Given this list of marker genes NRG3, VAT1L, ARHGAP12, SULT1E1, EXOC1, SYNJ2BP, RAI14, CAP2, CAPS2, CDKN2B, ADAM19, ZNF711, MGST3, AMOTL2, H2AC6, BEX4, TAGLN, TMEM144, NAP1L3 (NCBI Gene Id 4675), TP53INP2, PTPN14 (NCBI Gene Id 5784), DHRS3, MLLT11, SKP1, NT5E, TUBB2A, PRKCH, ZNF627, NREP, TRIM33, CFAP95, ABI3BP, SCG5, TMEM140, OSTF1 (osteoclast stimulating factor 1), KLHDC8A, C5orf15, SERINC1 (serine incorporator 1), MEAK7 (NCBI Gene Id 57707), ADGRD1, ACTA2, EVA1A, CCN1, PIKFYVE, LMBRD1, IFITM1, KRT18, RAB2B, GPR83, CAVIN1 (NCBI Gene Id 284119), FAM13B, AIG1, CYP26A1, ATP2B4, ATP6V1E1, TGFB2, ATAD1, HTN1, MKRN1, SETX, ITFG1, MYL12B, SCRG1, SLC30A9, ZNF540, RNF103 (NCBI Gene Id 7844), BDH2, ERVFRD-1 (NCBI Gene Id 405754), COX20, IFT52, HTN3, PELO, TPD52L1, PLSCR3 (phospholipid scramblase 3), CCNDBP1, GAB2, ARHGDIB, DKK2, PTPRH, CYLD, PLPP6, CCNG2, TRAFD1, UCHL1, FAM220A, SYT17, RUFY3, USP6, RWDD2A, FGF1, REG3G, ANK2, SNN, SH3BGR, CDK5R1, LANCL1, HIPK2, WNK4, EGR3, BCLAF3, SUSD6, PSEN1, NMRK1, SAMD9L, SLC12A6, FILIP1L, ZSWIM6, OTUD1, YPEL5, ATP9A, TUG1, FAT1, CCDC115, DTX4, GPRASP2, RARA, CFAP20, GNAQ, ATP6V1G1, C18orf32, ANO6, ST6GALNAC3, NCAM2, BCAS3, CXCL8, BMAL1, CTTNBP2NL, TDRP, IFITM3, SMIM14, RND3, RASA1, PICALM, FGD6, TRIM2, GNPTG, PHLDB2, GRB10, PLA2G12A, CD59, TRIM22, WDR47, CPNE3, SST, MAP1LC3B, SCN3A, UBE2A, ANXA3, MYH9, AKAP6, SMYD3, PJA1, GTF2A1, NUB1, AK9, GBP3, NAPB, PAPSS1, FOXC1, FSTL1, SPATA7, THBS2, TAGLN3, FSD1L, FN1, PRSS23, TMSB15B, MMD, PKIG, KLF3-AS1, HMGCL, ZNF419, ZNF879, ADAMTS15, ITGB1, H3C6, KDM7A, EMCN, PRORSD1P, CADPS (NCBI Gene Id 8618), IFNAR2, OPTN, CREM, GABARAPL1, ADM, GPRC5A, ZNF784, CLIP4, GAS2, IFI35, SMIM3, GARNL3, SERPINE1, LINC00847, ITGA2, NUAK1, SRPX, GFRA1, here is a description of the gene set: Genes up-regulated in double positive thymocytes with ELK4 knockout: untreated versus stimulated by anti-CD3. Human Gene Set: GSE21546_UNSTIM_VS_ANTI_CD3_STIM_SAP1A_KO_DP_THYMOCYTES_UP studied in species Homo sapiens from publication Costello P, Nicolas R, Willoughby J, Wasylyk B, Nordheim A, Treisman R (PMID 20554967) Removal of the transcription factor SAP1a member of the Ternary Complex Factor (TCF) group of transcription factors which in conjunction with Serum Response Factor (SRF) has been shown to have a profound effect on positive selection in the thymus. When another TCF Elk1 is knocked out in mice there is no effect on positive selection unless it is on a Sap1a KO background where the phenotype is very severe. We have stimulated isolated double positive T cells (DPs) with anti-CD3 to mimic positive selection and compared basal and stimulated transcription across the four genotypes to discover the downstream targets of Sap1a involved in positive selection.